Given this list of marker genes HLA-G, TGFBR2, PDCD1, LILRB2, IL2RA, CLC, HAVCR2, HLA-B, MARCHF7, HMGB1, CBLB, FOXJ1, PHLPP1, FOXP3, LILRB4 (NCBI Gene Id 11006), IRAK3, NR5A2, IDO1, ITCH, CD3E, here is a description of the gene set: Human Gene Set: GOBP_REGULATION_OF_TOLERANCE_INDUCTION species: Homo sapiens Any process that modulates the frequency, rate, or extent of tolerance induction.